The following is a description of a gene set: Human Gene Set: HP_ABNORMAL_PARATHYROID_MORPHOLOGY studied in species Homo sapiens A structural abnormality of the parathyroid gland. Abnormal parathyroid morphology, and this is the list of marker genes: TBX1, GATA3, CDKN1B, CLCNKB, TSC1, CASR, IFNG, CDKN2C, RET, CDKN2B, PRDM10, ZFX, CDKN1A, CHD7, IDH1, KL, NF1, IDH2, GCM2 (NCBI Gene Id 9247), MEN1, CDC73, SLC12A3, TSC2, FLCN